The following is a description of a gene set: The process in which the anatomical structures of the forebrain are generated and organized. The forebrain is the anterior of the three primary divisions of the developing chordate brain or the corresponding part of the adult brain (in vertebrates, includes especially the cerebral hemispheres, the thalamus, and the hypothalamus and especially in higher vertebrates is the main control center for sensory and associative information processing, visceral functions, and voluntary motor functions). species: Mus musculus Mouse Gene Set: GOBP_FOREBRAIN_MORPHOGENESIS, and this is the list of marker genes: Hhex, Smo, Gsx2, Wnt5a, Sox2, Ift88, Otx2, Uchl5, Prop1, Nf1, Fgf8, Hesx1, Gak, Duox2, Pten, Otx1, Tuba1a, Gdf7